The following is a description of a gene set: from publication Ramilo O, Allman W, Chung W, Mejias A, Ardura M, Glaser C, Wittkowski KM, Piqueras B, Banchereau J, Palucka AK, Chaussabel D (PMID 17105821) Each infectious agent represents a unique combination of pathogen-associated molecular patterns that interact with specific pattern-recognition receptors expressed on immune cells. Therefore, we surmised that the blood immune cells of individuals with different infections might bear discriminative transcriptional signatures. Gene expression profiles were obtained for 131 peripheral blood samples from pediatric patients with acute infections caused by influenza A virus, Gram-negative (Escherichia coli) or Gram-positive (Staphylococcus aureus and Streptococcus pneumoniae) bacteria. Thirty-five genes were identified that best discriminate patients with influenza A virus infection from patients with either E coli or S pneumoniae infection. These genes classified with 95% accuracy (35 of 37 samples) an independent set of patients with either influenza A, E coli, or S pneumoniae infection. A different signature discriminated patients with E coli versus S aureus infections with 85% accuracy (34 of 40). Furthermore, distinctive gene expression patterns were observed in patients presenting with respiratory infections of different etiologies. Thus, microarray analyses of patient peripheral blood leukocytes might assist in the differential diagnosis of infectious diseases. Genes up-regulated in comparison of peripheral blood mononuclear cells (PBMC) from healthy donors versus PBMC from patients with acute S. aureus infection. studied in species Homo sapiens Human Gene Set: GSE6269_FLU_VS_STAPH_AUREUS_INF_PBMC_UP, and this is the list of marker genes: LRIF1, IGHM, PAN2, LBH, LARP4, RPP40, COPB2, DIDO1, ORC2, POLR2H, PWWP3A, ZNF544, CD22, RFTN1, SUN2, OARD1, SPECC1L (NCBI Gene Id 8221), PRR5L, DBT, ZNF638, NUDCD3, LDLRAP1, SIDT1, ST6GAL1, PCDH9, ZBTB3, RPS6KA5, GIMAP5, FCRL2, RAD52, TMEM63A, KLF2, PTPRK, P2RX5, LZTFL1, AIRIM (AFG2 interacting ribosome maturation factor), MPHOSPH8, CIITA, PSD4, BRWD1, PDHB, OGFOD2, COBLL1, GLS, DCAF8, ING4, AKTIP, LRRN3, HLA-DOB, FAM3C, BNIP3, CCR9, CD19, IPP, MTMR4, RPAP2, TMEM156, ESYT1, BCL11A, NAT10, CD72, PBXIP1, CR2, NMT2, COA1, NXF1, SLC25A17, ZNF514, SNRNP70, POLG2, ADA, SPDL1, COX11 (NCBI Gene Id 1354), CYB5A, RAB3GAP2, ERCC3, ITPKB, DNAJC11, ABCB4, ETAA1, TTC9, PLS3, CDK13, NUMA1, GGA2, ALDH5A1, PILRB, TRMT13, TRAC, EZH1, KAT2A, BANP, ZNF45, TSPAN3, CYP2R1, WDR77, JAK1, OSBPL10, JADE2, KHDC4, SPIB, NEK9, EIF2B5, INPP5D, SMC6, CSNK1D, DNAJC24, GPR18, CIAPIN1, ZMYND11, AGMAT (agmatinase (putative)), SFI1, ARHGAP45, SAP25, MAPRE2, NCOA3, JPT2, WDR82, LAX1, METTL4, CEP83 (NCBI Gene Id 51134), ARHGAP25, SLC25A12, RBM8A, RUBCN, GSDMB, AHSA1, SLC5A3, DNAJA3, LRRC1, NOP14, LAT, TRIM32, TMEM204, RPA2, ZBTB24, POLR1HASP, DVL2, PIGG, ZNF500, HMCES, HIVEP2, ZBTB40 (zinc finger and BTB domain containing 40), TFB1M, RBM5, IL16, ORC5, GATA3, RASGRP2, ZNF692, PTCD3, MTSS1, ZNF175, CCT4, MORC2, DNAJC16, BLK, FAM193A, TCF3, TAF1B, PRKD2, TMCO6, CD27, DIPK1A, NPAT, ADARB1, PRRC2B, GPM6A, LY9, ENTR1, PDCD11, BTN2A1, TLE1, PAWR, ZKSCAN7, CBX7, NHLRC2, SEMA4D, LRCH3, SYNRG, SH2B1, PPOX, GPA33